The following is a description of a gene set: Th1 and Th2 cells arise from a common precursor cell in response to triggering through the TCR and cytokine receptors for IL-12 or IL-4. This leads to activation of complex signaling pathways, which are not known in detail. Disturbances in the balance between type 1 and type 2 responses can lead to certain immune-mediated diseases. Thus, it is important to understand how Th1 and Th2 cells are generated. To clarify the mechanisms as to how IL-12 and IL-4 induce Th1 and Th2 differentiation and how TGF-beta can inhibit this process, we have used oligonucleotide arrays to examine the early polarization of Th1 and Th2 cells in the presence and absence of TGF-beta after 0, 2, 6 and 48 hours of polarization. from publication Lund R, Aittokallio T, Nevalainen O, Lahesmaa R (PMID 14607935) Human Gene Set: GSE2770_IL4_ACT_VS_ACT_CD4_TCELL_6H_UP studied in species Homo sapiens Genes up-regulated in CD4 T cells activated by anti-CD3 and anti-CD28: IL4 (6h) versus untreated (6h)., and this is the list of marker genes: MPPE1, TMEM39B, SLC16A6, ANXA6, VAMP2, NEDD9, NDUFA10 (NCBI Gene Id 4705), MIF4GD, LAMTOR1, IDH3G, CAMK2G, NEDD8, SLC39A11 (solute carrier family 39 member 11), HDDC3, BNIP3L, DMAC1, RCL1, EXOC4, GGTA1, AP1M1, TOE1, NUDT1, P2RY13, DIS3L, SASH3, NME3, EPRS1, APEX1, SLC38A10, ALDH3B1, FAM228B, ERICH1, FGL2, NR4A3, COPS2, ARPIN, WDR18, WAS, FAM204A, TTC7A, TOR2A (NCBI Gene Id 84633), ANP32A, AMT, SLC18B1, IFITM1, ERP27, MPP7, RNF7, RIOK3, BACE1, CMTM2, GPR160, F5, ANO2, POLB, POLM, LIN7A, CS, GARS1-DT, VCL, ABHD17A, TKT, ARL5A, GIMAP2, SIMC1P1, MCM5, LAMTOR4 (NCBI Gene Id 392758), STN1, KLF2, EZR, REPS2, ID3, NMD3, TMC8, H2AJ, MIB2, THYN1, MAPRE2, ANAPC15, ZBED10P, C3orf33, P2RY8, STX16 (syntaxin 16), BCL6, ABHD14B, EIF2AK1, MIDEAS, SF1, DPH7 (diphthamide biosynthesis 7), A1BG, ALAD, MZT2A, OGFOD3, FCGR1A, DUSP23, NDUFS7, MSRB2, RASAL3, SIDT1, CAPN3, VSIG4, PSMB9, RAB3D, CRISPLD2, FAM216A, LMO4 (LIM domain only 4), HDHD5, SPSB3, PEBP1, IGFBP7, IL12RB1, RPIA, HLA-DRB6, SIVA1, DUT, FBXL17, PRKX, RWDD1, ZNF91, OR52K3P, MBNL1-AS1, TAGLN2 (NCBI Gene Id 8407), BHLHE40, GPBAR1, ACOT8, PCED1A, RERE, SUMF2, NREP, PHF19, R3HDM1, AOC1, NR4A1, TEX264, SLC25A45, PTGS2 (prostaglandin-endoperoxide synthase 2), PGAP2, TCF3, APOBEC3B, CAPNS1, MBOAT1, MAP4K1, ATP5ME, NDST1, SRSF5, NAPSB, GNG2, C11orf21, SLC2A3, FXYD5, NAA38, IFI44, ERN1 (endoplasmic reticulum to nucleus signaling 1), RCSD1, ADD3, ESYT1, CTPS2, HCG27, ALDH1A1, ZSWIM7, ERP29, KBTBD11, SIDT2 (NCBI Gene Id 51092), WDR17, VEGFA, DENND1C, PADI2, JMJD1C, TLE3, SLC2A4RG (NCBI Gene Id 56731), RASGRP2, BMF, UQCRC2, JUP, PIGS, DHPS, COPS6, PTPN22, NLRC5, HLA-DRA, KANSL2, FCGR1BP, TXNDC11, MRPL40, ZNF362, S1PR3, KLF7, TM7SF3, ASGR2, FBP1, CMC4, SLC9A9, SELENOP, PTS, MTX1, ABCA7, CIDEB, ARL4C, IFI44L